The following is a description of a gene set: Digestion of dietary lipid species: Mus musculus Mouse Gene Set: REACTOME_DIGESTION_OF_DIETARY_LIPID, and this is the list of marker genes: Clps, Pnliprp2, Lipf, Pnlip, Pnliprp1 (NCBI Gene Id 18946), Cel